Given this list of marker genes PWRN1, RDH12, SNRNP200, YY1, RNF125, STAT6, ROM1, ARL6, AHI1, USH2A, PDX1, SNORD116-1, RLBP1 (NCBI Gene Id 6017), IMPDH1, MERTK, GLUD1, RGR, ZNF513, KDM6A, INSR, RPE65, PLAAT3, CERKL, KCNJ11 (potassium inwardly rectifying channel subfamily J member 11), AKT2, POMGNT1, SLC7A14, ZFP57, HADH, PRPF31, POMC, AGBL5, PDE6G, SPATA7, KIZ, PRPH2, PROM1, PAPPA2, GALK1, CA4, SEMA4A, RBP3, LEP, PPARG, DMXL2, RP2, APPL1, BBS2, NEUROD1, PRPF6, NRL, SH2B1, IFT140, ADCY3, HNF4A (NCBI Gene Id 4339), IMPG2, GUCA1B, INS, LRAT, PDE6B, RHO, LEPR, HERC2, CNGA1, DBH, NPAP1, ZMPSTE24, AHR, CPE, KIAA1549, PDE6A, NR2E3, RP9, SMC5, IDH3A, SCAPER, SIM1, HNF1A, PLAGL1, PRPF4, MKRN3, ABCA4, ABCC8, AGPAT2, PRPF8, SNORD115-1, NAB2, IMPG1, PCYT1A, KLHL7, CFAP418, CAV1, CNGB1, MAGEL2, PWAR1, BBS1, ARL3, RPGR (retinitis pigmentosa GTPase regulator), REEP6, HGSNAT, CAVIN1, MAK, CLRN1, CRB1, ZNF408, TULP1, CRX, MPI, MAFA, BSCL2, SLC25A36, KLF11, NEK2, PLIN1, EYS, MEN1, FOS, TRMT10A, CDHR1, ARHGEF18, SLC16A1, ALMS1, LMNA (NCBI Gene Id 7816), DHDDS, FAM161A, TUB, ARL2BP, TTC8, PRCD, DHX38, CC2D2A, FOCAD, CDKN1B, CEL, IFT88, KMT2D, RP1, RP1L1, PRPF3, PAX4 (NCBI Gene Id 5078), MC4R, GCK, SAG, SLC5A2, TOPORS, OFD1, DIS3L2, BLK, PCARE, UCP2 (uncoupling protein 2), ESR1, PMM2, FSCN2, SECISBP2, IDH3B, PCSK1, BEST1, IFT172, HYMAI, here is a description of the gene set: An abnormal concentration of insulin in the body. studied in species Homo sapiens Abnormal circulating insulin concentration Human Gene Set: HP_ABNORMAL_CIRCULATING_INSULIN_CONCENTRATION